The following is a description of a gene set: The cycle from wakefulness through an orderly succession of sleep states and stages that occurs on an approximately 24 hour rhythm. species: Homo sapiens Human Gene Set: GOBP_CIRCADIAN_SLEEP_WAKE_CYCLE, and this is the list of marker genes: GHRH, HCRTR2, BTBD9, NPY2R, NLGN1, PER3, PTGDS, NMU, PARP1, FXR1, GABRB3, KCNA2, GHRHR, CSF2, CHRNB2, CRH, MTNR1B, PLN, ADORA2A, NPS, ADORA1, ADRB1, BLOC1S6, NR1D1, GHRL, DRD2